Given this list of marker genes NCOA4, REXO2, KIAA1143, PARVA, SRGAP2C, PRKAA1, CCNB1, PLS1, CDYL, NKTR, EPHA7, BNIP2, HDGFL3, RAPGEF5, GABRG2, USP54, LMNTD1, ODAM, RSBN1, RPEL1, PSMA8, HERPUD2, DEPDC1, DMXL2, CTDSPL2 (CTD small phosphatase like 2), SRGAP2B, ATP10B, BTBD1, SAR1B, HOMER1, GDAP2, RAD21, NFIB, CNTN4, PCMTD1, OSBPL3, SF3B1, SNAP25, EED, here is a description of the gene set: from publication Chen Y, Wang X (PMID 31504780) Genes predicted to be targets of miRBase v22 microRNA hsa-miR-4661-5p in miRDB v6.0 with MirTarget v4 prediction scores > 80 (high confidence targets). studied in species Homo sapiens Human Gene Set: MIR4661_5P